The following is a description of a gene set: part of: Peptide hormone metabolism Reactome Pathway: Synthesis, secretion, and deacylation of Ghrelin electronically inferred by orthology from the curated human pathway This event has been computationally inferred from an event that has been demonstrated in another species.<p>The inference is based on the homology mapping from PANTHER. Briefly, reactions for which all involved PhysicalEntities (in input, output and catalyst) have a mapped orthologue/paralogue (for complexes at least 75% of components must have a mapping) are inferred to the other species. studied in species Mus musculus, and this is the list of marker genes: Gh, Lep, Ins2, Sec11c, Spcs2, Bche, Ins1, Gcg, Spcs3, Spcs1, Pcsk1